Given this list of marker genes FBXO28, MAST3, SCN1B, KCNC2, COQ8A, SCN1A, PEX5 (peroxisomal biogenesis factor 5), GOSR2, GABRG2, BRAT1, ASAH1, KCTD7, SLC38A3, POLG, PDE2A, TEFM, TWNK, VAMP2, SLC2A1, SCN9A, CACNA1A, SCN2A, MRM2, GABRA1, SYNJ1, SLC1A2, PCDH19, CNTNAP2, PDSS2, DEPDC5, here is a description of the gene set: Human Gene Set: HP_STATUS_EPILEPTICUS_WITH_PROMINENT_MOTOR_SYMPTOMS Status epilepticus with prominent motor symptoms studied in species Homo sapiens Status epilepticus with prominent motor signs during the prolonged seizure.